The following is a description of a gene set: from publication Chen Y, Wang X (PMID 31504780) Genes predicted to be targets of miRBase v22 microRNA hsa-miR-4804-5p in miRDB v6.0 with MirTarget v4 prediction scores > 80 (high confidence targets). studied in species Homo sapiens Human Gene Set: MIR4804_5P, and this is the list of marker genes: GNB1 (G protein subunit beta 1), FAM169BP, NUS1, ADO, GBGT1, NCOA2, CCDC180, SETD9, CES2